The following is a description of a gene set: Mouse Gene Set: GOBP_CELLULAR_RESPONSE_TO_INTERFERON_ALPHA species: Mus musculus Any process that results in a change in state or activity of a cell (in terms of movement, secretion, enzyme production, gene expression, etc.) as a result of an interferon-alpha stimulus. Interferon-alpha is a type I interferon., and this is the list of marker genes: Ifnar1, Pde12, Ifi204, Ifit1, Oas1g (NCBI Gene Id 23960), Oas1c, Oas1e, Oas1f, Traf3ip3, Ifit2, Oas1d, Star, Oas1h, Tpr, Gas6, Ro60, Oas1a, Myc, Oas1b, Gata3, Axl